The following is a description of a gene set: Any process that stops, prevents, or reduces the frequency, rate or extent of the chemical reactions and pathways involving amines. studied in species Homo sapiens Human Gene Set: GOBP_NEGATIVE_REGULATION_OF_AMINE_METABOLIC_PROCESS, and this is the list of marker genes: MIR21, ATP2B4, ITGAM, ATP7A, NT5DC2 (NCBI Gene Id 64943), ITGB2, SNCA